Given this list of marker genes NRP2, LMAN2L, P4HA1, CEBPG, CBLN4, RALGPS1, ESYT2, HIC1, ZRANB2, TACC2, COL4A1, ANXA11, DMRT1, STAT3, DCTN4, PRRX1, RWDD4, ACVR2A, STAG2, MBOAT2, SMARCAD1, ERF, DTNA, EYA1, DESI2, CTNS, TRAM2, CERS2, EBF3, ARK2C, PRRC1, TOB2, GLT8D1, RHOG, ZBTB39, FOXQ1 (forkhead box Q1), AKAP1, SPRY2, MMD2, SLBP (NCBI Gene Id 7884), NEUROD1, NFIB, KCNK2, RTN3, LMBRD2, CCND2, FAM78A, MITF, EMD, TCF3, ABR, ULK2, EPN2, RBMS1, PTPN9, SNCAIP, ETS1, OSBP, PDE2A, IGDCC4, SESTD1, C1GALT1, RFX1, RAB43, MYH9, ROCK2, TMEM168, NEXMIF, MPC1, NCOA7, SRGAP3, SNX6, CELSR3 (NCBI Gene Id 1951), RFFL (NCBI Gene Id 117584), AHNAK, ARPC5, ANKRD13A, PID1 (NCBI Gene Id 55022), ADIPOR2, DCAF12L1, MACROD2, RXRA, C1orf21, PLCXD3, SLC35F5, EFCAB14, MARCHF7, WDFY3, MED26, EXTL3, ELAVL1, PLAGL2, PNN, MAPRE1 (NCBI Gene Id 22919), PPM1F, BACH2 (BTB domain and CNC homolog 2), RPIA, SEPTIN11, KCNK10, SH3BP5L, LCLAT1 (lysocardiolipin acyltransferase 1), PARP1, PDZD2, PCGF5, ZSCAN18, SLC25A20, OSBPL11, CACNB3, ZNF580, KLF13, SLC16A14, TOR3A, LRP6, HDAC4, DICER1, RUNX2, WIPF2, CASC3, BCL2L11, FAM177A1, STK4, LHX2, SERTAD4, VANGL1, MPZL1, NAV2 (neuron navigator 2), PCDH8, ITGA11, WIPF1, PLEKHH1, TMED1, DUSP6, ELK4, OTUD4, VAT1L, SPINDOC, RERE, C5orf24, SASH1, CDR2L, AKT3, CCDC28A (NCBI Gene Id 25901), USP14, NEGR1, BACE1, TMEM178A, MYH10, OSBP2, SEMA6C, KANK1, ZCCHC14, OXSR1, PIK3CA, ZNF3, MECOM (NCBI Gene Id 4197), RBM33, ANKFY1 (ankyrin repeat and FYVE domain containing 1), JPH1, TSPOAP1, PALLD, SGCD, PDE4A, TEAD1, JAZF1, MTMR12, PPP6R3, TACC1, DHCR24, GNPDA2, OPN3 (opsin 3), MORC4, ERMP1, ATP7A, PTPN1, PLXNA3, CCDC6, AFF4, ANTXR2, TMEM263, PTPN12, ITPR3, SH2B3, SLC27A1, COL12A1, JAKMIP3, OSBPL3, ANGEL1, ZDHHC3, B4GALT1, RAB11A, ICMT, ZNF219, JAKMIP1, SPECC1L, MYNN, MYRF, ACSL1, ETV1 (NCBI Gene Id 221810), CLDN11, MFSD14B, SLC31A2, THAP2, KCNQ2, WDFY1, RAVER1, CREB1, ANXA5, NDFIP1, PLSCR3, CBFB, MYADM, LPP, CNN3, PEG3, KIAA0408 (NCBI Gene Id 9729), MYADML, MKLN1 (NCBI Gene Id 55782), PAPOLG, SREK1, GIT2, LONRF1 (LON peptidase N-terminal domain and ring finger 1), DYNC1LI1, SEMA6A, MAPK4, DYNLT3, SEC13, VCF1, EPHX4, NUP58, CNTN1, GRM1, DIAPH2, COTL1, HMGXB4, SERTAD3, BAZ2B, FLOT2, ZNF772, SELENOS, MAPK14, SCD, DPY19L3, LRRC1, ITGA7, ELOVL5, ARFGEF3, P4HTM, SCAMP2, ARHGEF4, EZH2 (NCBI Gene Id 392834), SOX12, GOLM2, EN2, STRN3, OGT, TTL, RALGPS2, SLC1A4, VSNL1 (visinin like 1), FARP1, SERP1, LYSMD3, ZNF148, GPC4, FERMT2, MYCBP, RSRC2, TMEM129, SLC9A6, TOX, LPCAT3, MTPN, PTBP3, GAS2, CSNK1G1, SNX4, SOX9, GGA1, HTR2C, LPIN1, RHBDL3, ANGPT1, NKAIN2, CCDC177, HIPK1, GPM6B, MOCS1, SERINC2, TUBG1, CCL2, SLC7A8, CHSY1, GZF1, RALA, SLITRK6 (NCBI Gene Id 84189), EGR2, NR3C1, FAM219A, ELL2, EYA4, MYORG, TRPS1, LRRC57, EDEM1, LITAF, FZD8, SLC31A1, MLLT3, PHF6, LMF2 (NCBI Gene Id 91289), CUL5, PPP1R13L (NCBI Gene Id 23453), ARHGEF7, ZDHHC20, RYR2, APBB2, YEATS2, WASF1, CHODL, LIMCH1, MARK1, NFIX, RREB1, REEP1, CADPS, HEPACAM, FGFR2, NR5A2, PHTF2, CHST1, YOD1, AHR, MARCHF8, HDAC5, MYO1C, SORD, EPHA3, ZBED4, NAV1, ADCY1, PLIN3, TFDP2, VAT1, MAP7, DDX6, GLCE, RAVER2 (NCBI Gene Id 89143), DMD, NACC1, LIN28B, RANBP10, MINAR1 (NCBI Gene Id 23251), OGFOD3, CHP1, ZDHHC16, CACNA2D2, RASGEF1A, TEX261, BLOC1S6, DENND1B, PPP6R2, IQGAP1, SLC48A1, NAA15, ARHGDIA, SAMD4B, CSTF3, CEP350, ETF1, ABCA2, UBE2B, PPTC7, SUCLG2, ZNF608, SIRT1, PGRMC2, FNBP1L (formin binding protein 1 like), RAI14, TLL1, MEA1, EMP2, SRSF6, E2F6, STK35, CTDSPL, MYRIP, ZNF706, TMEM134, ZCCHC24, NFATC1, MAGT1, LARP4B, AK3, MAP1B, B4GALT6, GDAP2, MECP2, SIX4, DIAPH1, PARP16, SLC35B2, SURF4, STC1, RBM24, IST1, PMEPA1, F11R, PPARA, EDNRB, TSHZ2, GNA13, CNTN3, PCYOX1, SP3, ASB1, DMXL1, DNAJC1, CACNB2, ALCAM, CAPN6, FAM222B, FAM53B, ANXA7, VAMP3, VMP1, KLHL17, NPTN, PPP2R5E, PDXK, GRIA3, ASCC2, FAM210A, RGS9 (NCBI Gene Id 8787), LEMD3, SP2, MAP2K4, PIEZO2, GRIA2, TMEM184B, PDCD6, DNAJB12, ARG2, SLC10A7, PRKD1, NCKIPSD, PTBP2, LCOR, RAB34, PCSK6, ATF7IP, USP48, PTBP1, TMEM109, GGA2, LARP1, AKT1S1, RNF11, NXT2, KLHL24, MACF1, ARGLU1, SART3, BMP6, CD164 (NCBI Gene Id 8763), AMMECR1, AAK1, PTTG1IP, CDON, XPO4, NAV3, RNF144A, CCDC117, ABTB3, SLC4A7, HBP1, RYR3, CDK6, SYNC, YIPF6, RAD17, FAR1, ABHD3, TMCC3, CHMP2B, SCN4B, GAS2L1, KLF4, SELENOI, SEMA6D, FBXO30, JAG1, RAB27A, RAB6C, EYA2, PTPRE, LMNA, ELK3, LAMC1, XKR6, RPS6KB1, MTDH, RBMS3, SUGT1, ATP6V0A2, DUSP15, TBC1D9B, SEC61A2, ABCC4, ALG2, DYNC1LI2, RAB14, SNIP1, SIGMAR1, OSBPL6, BAHD1, RAP2A, MYLIP, VPS37B, BRD4, KCTD12, SP1, FRMD4A, SLC16A1, FA2H, ELAPOR2, TUBB6 (tubulin beta 6 class V), MYO10, RAB6A, PEA15, GLTP, GRID1, GPR85, MAP3K3, PAQR8, RRBP1, QKI, NFASC, CPNE5, TPD52L2, THRB, AP3M1, EFNB2, RAB10, CGN, BRWD1, PSEN1, KCNJ2, CAPN2, CDK18, ATMIN, RNF128, LRIG1, NPLOC4, here is a description of the gene set: Human Gene Set: TGCCTTA_MIR124A Genes having at least one occurence of the motif TGCCTTA in their 3' untranslated region. The motif represents putative target (that is, seed match) of human mature miRNA hsa-miR-124a (v7.1 miRBase). species: Homo sapiens